The following is a description of a gene set: The chemical reactions and pathways involving GMP, guanosine monophosphate. Mouse Gene Set: GOBP_GMP_METABOLIC_PROCESS studied in species Mus musculus, and this is the list of marker genes: Ppat, Xdh, Guk1, Gmpr2, Ampd1 (adenosine monophosphate deaminase 1), Ada, Paics, Gart, Impdh2, Adk, Gmps, Gda, Urad, Ampd2, Pals2, Uox, Pals1, Impdh1, Pnp, Hprt1, Urah, Aprt, Pfas, Nt5c2, Adsl, Atic